Given this list of marker genes NPIPA1, SREBF2, BPTF, MX2, HESX1, ISG15, PDHX, HERC6, VPS39 (NCBI Gene Id 23339), AP3D1, PKM, SZT2 (NCBI Gene Id 79597), ACTN4, H2BC17, AGRN, MRTFA, PARP12, UBA7, EMP3, ERGIC2, UBA1, ARPC1A, ATP13A1, IFITM3P7 (IFITM3 pseudogene 7), KCTD13, LRRFIP1, KDELR1, SPATS2L, CALR, CCR5, RSAD2, TMEM255A, MOGS, C2CD3, TRABD, MTDH, PROSER1, SMG7, CMTR1, IFITM3, USP10, RPN2, LGALS3BP, RFWD3, LMNB1, IFI44, PRR13, CES1, EIF2AK2, TKFC, IFI35, ACIN1, IFI6, IRF3, ZYX, EIF4G1, COPS7A, PSME3, DNM2, RNF40, GOLGA2, YWHAE, ADAR, CAPN3, HACD3, STRN4, PPIG, ARHGDIA, CHST12, MYO9B, NBPF14, NFATC2IP, SART3, RUSF1, PI4KB, DCTN1, RUBCN (NCBI Gene Id 9711), HLA-B, NUP62, TLN1, HECTD3, WIPF1, POLM, GPATCH8, MX1, SZRD1, OAS2, FFAR2 (free fatty acid receptor 2), LIMD2, TRIM21, IFITM2, DNAJC4, USP1 (ubiquitin specific peptidase 1), CXXC1, NRBP1, DLGAP4, TGFB1, MAU2, CDC27, TRIM14, IDS, PANX1, POU2F2, GMIP, IFI44L, CCND3, LARP1, GSE1, PURA, MYO18A, IFITM1, MLEC, ATP2A2, CAPN15, USP11, NBEAL2, XAF1, BRD2, MIR3648-1, GLYR1, WAS, OAS3, TRIM38, CD74, SIGLEC1, SLC4A2, HLA-A, PIAS1, OASL, HLA-J (major histocompatibility complex, class I, J (pseudogene)), GNAI2, N4BP1, PHACTR2, PDIA6, GAK, MMP9, MARK2, ZSWIM8, IRF7, USP18, ACTB, TYK2, GTPBP2, SUPT6H, ZBP1, OGDH, KMT2B, NUCB1, TMBIM6, ZNF37A, EBAG9, OAS1, F8A1, PTK2B, CNOT3, NCOA6, TMT1A, COMT, DCAF15, SHFL, SH2B2, IFI16, DDX60, SHC1, here is a description of the gene set: Each infectious agent represents a unique combination of pathogen-associated molecular patterns that interact with specific pattern-recognition receptors expressed on immune cells. Therefore, we surmised that the blood immune cells of individuals with different infections might bear discriminative transcriptional signatures. Gene expression profiles were obtained for 131 peripheral blood samples from pediatric patients with acute infections caused by influenza A virus, Gram-negative (Escherichia coli) or Gram-positive (Staphylococcus aureus and Streptococcus pneumoniae) bacteria. Thirty-five genes were identified that best discriminate patients with influenza A virus infection from patients with either E coli or S pneumoniae infection. These genes classified with 95% accuracy (35 of 37 samples) an independent set of patients with either influenza A, E coli, or S pneumoniae infection. A different signature discriminated patients with E coli versus S aureus infections with 85% accuracy (34 of 40). Furthermore, distinctive gene expression patterns were observed in patients presenting with respiratory infections of different etiologies. Thus, microarray analyses of patient peripheral blood leukocytes might assist in the differential diagnosis of infectious diseases. species: Homo sapiens Human Gene Set: GSE6269_FLU_VS_E_COLI_INF_PBMC_UP from publication Ramilo O, Allman W, Chung W, Mejias A, Ardura M, Glaser C, Wittkowski KM, Piqueras B, Banchereau J, Palucka AK, Chaussabel D (PMID 17105821) Genes up-regulated in comparison of peripheral blood mononuclear cells (PBMC) from patients with acute influenza infection versus PBMC from patients with acute E. coli infection.